The following is a description of a gene set: Discrimination between self vs. non-self and adequate response to infection and tissue damage are fundamental functions of the immune system. The rapid and global spread of known and emerging viruses is a testament that the timely detection of viral pathogens that reproduce within host cells, presents a formidable challenge to the immune system. To gain access to a proper reproductive niche, many pathogens travel via the host vasculature and therefore become exposed to humoral factors of the innate immune system. Although a cascade of coagulation factors plays a fundamental role in host defense for “living fossils” such as horseshoe crabs (Xiphosurida spp), the role of the coagulation system in activation of innate responses to pathogens in higher organisms remains unclear. When human type C adenovirus (HAdv) enters the circulation, 240 copies of coagulation factor X (FX) bind to the virus particle with picomolar affinity. Here, using molecular dynamics flexible fitting (MDFF) and high resolution cryo-electron microscopy (cryo-EM), we defined the interface between the HAdv5 hexon protein and FX at pseudo-atomic level. Based on this structural data, we introduced a single amino acid substitution, T424A, in the hexon that completely abrogated FX interaction with the virus. In vivo genome-wide transcriptional profiling revealed that FX-binding-ablated virus failed to activate a distinct network of the early response genes, whose expression depends on transcription factor NFKB1. Deconvolution of the signaling network responsible for early gene activation showed that the FX-HAdv complex triggers MyD88/TRIF/TRAF6 signaling upon activation of toll-like receptor 4 (TLR4) that serves as a principal sensor of FX-virus complex in vivo. Our study implicates host factor “decoration” of the virus as a mechanism to trigger innate immune sensor that respond to a misplacement of coagulation FX from the blood into intracellular macrophage compartments upon virus entry into the cell. Our results further the mounting evidence of evolutionary conservation between the coagulation system and innate immunity. Human Gene Set: GSE36078_UNTREATED_VS_AD5_INF_MOUSE_LUNG_DC_DN Genes down-regulated in CD11c+ monocytes: control versus HAdv5 infection. from publication Doronin K, Flatt JW, Di Paolo NC, Khare R, Kalyuzhniy O, Acchione M, Sumida JP, Ohto U, Shimizu T, Akashi-Takamura S, Miyake K, MacDonald JW, Bammler TK, Beyer RP, Farin FM, Stewart PL, Shayakhmetov DM (PMID 23019612) species: Homo sapiens, and this is the list of marker genes: FHIP2A, KNL1, GALNT14 (NCBI Gene Id 79623), KLRD1, AIMP2, PADI2, IL12RB1, TXNDC16 (NCBI Gene Id 57544), PPIF, PPP2CB, E2F7, DDIAS, SMTN, VCL, DSCC1, RELL1, GPR25, SGO1, NEURL1B, FKBP2, DOLK, MTMR1, ZDHHC18, ITGA2, SELENON, SLC16A6, PRKAR2A, GLUL, ANAPC11, PIH1D1, ANKRD50, H2AZ1, EEIG1, NEDD1, PPP1R18, TSKU, MAD2L2, C1orf174, CDKN1A, IRAK2, AIDA, CHST11, HOPX, ELMO2 (NCBI Gene Id 63916), ATP1A2, SLC22A5, KCNK6, DENND2C, ULBP1, CCNA2, MEF2D, DTNBP1, NCBP2, ILDR1, AJUBA, RAP2A, LXN, PPP3CA, UPK1A, PIK3AP1, SWAP70, FES, RHOC, DNAJC15, MXI1, CLCN5 (NCBI Gene Id 90056), FOXN3, IRF8, CEP76, NQO2, DPYSL2 (NCBI Gene Id 1808), OSBPL3, SLIT2, ZDHHC15, LFNG, FLNB, PRIM1, SMC4, THY1, DIPK1A, EHD1, GPC1, CDCA3 (cell division cycle associated 3), CHTF18, MACIR, FNIP2 (folliculin interacting protein 2), NUP205, WASHC5, SLC7A8 (solute carrier family 7 member 8), CBX4, SNHG3, NTAN1, CCNB2, NHSL2, PLS3, VIM, HAAO, IL2RA, DNAAF2, PRKAG1, MAP3K21, STT3A, TRAPPC8, UST, POP4, FCER1G, NIF3L1, SERPINI1, SYNE3, ID2, C1GALT1, CHD7, VAX2, PAK6, C2orf69, GNA11, GLRX, ARL4C, TGM3, POC1A, FBXO27, KCTD9, SIKE1, ERRFI1, DLEU7, GEM (NCBI Gene Id 2669), GPN2, TBX21, VWA7, MAPK3, RXRA, SLC43A3, MOB4, RRAS2, PCYT1A, DOCK5, CD86, CCL21, GRIN2D, AIP, CENPE, GRAMD2B, SEPTIN11, KNSTRN, SYTL2, KIF4A, PTPRK, HSD11B1, MXD3, SPIC (Spi-C transcription factor), DAPK2, RCBTB2 (NCBI Gene Id 1102), NCCRP1, AZI2, SAMSN1, AOPEP, AK3, ARL4D, NT5C3B (NCBI Gene Id 115024), GJA4 (gap junction protein alpha 4), GPSM2, ST3GAL6, KIF18B, STK10, SNX9, RIOX2, GBP7, RNPEP, PEA15, TBL2 (NCBI Gene Id 27203), CKAP2L, IFITM3, RCN1, CISD1, BAZ1A, HYCC2, IQGAP3 (IQ motif containing GTPase activating protein 3), CUTA, CCL4, NUCB1, DIMT1, BRD9, ZEB2, KAT7, TMEM14C, NYAP1, GXYLT1, COX7A2, SLC23A2, BARD1, DCBLD2 (NCBI Gene Id 131566), RSPH4A, MEF2A, COX5A, REC114 (REC114 meiotic recombination protein), DGAT1, KATNBL1, MMP16, SMC2, BMX